The following is a description of a gene set: Human Gene Set: GOBP_PTERIDINE_CONTAINING_COMPOUND_BIOSYNTHETIC_PROCESS The chemical reactions and pathways resulting in the formation of any compound containing pteridine (pyrazino(2,3-dipyrimidine)), e.g. pteroic acid, xanthopterin and folic acid. species: Homo sapiens, and this is the list of marker genes: DHFR, FPGS, MTHFS, PCBD1 (NCBI Gene Id 5092), MTHFD1, ATIC, QDPR, MTHFD1L, GCH1, PCBD2, SPR, DHFRP1, DHFR2 (NCBI Gene Id 200895), SLC46A1, PTS, FOLR1